Given this list of marker genes HNRNPH2, KMT2A, ZNF263, CDCA7L, DMD, POU3F2, JADE1, ZCCHC14, VCL, H4C3, MARCHF1, SEC14L1, HPSE2, OR2L13, JMJD1C, NKX2-8, TTLL10, ANKS1B, JOSD1, ANKS1A, CELF6, IKZF5, PRDM13, ADRB2, MAP2K5, TAF11, MBNL1, CBX8, TMEM187, ASIC1, NPAS2, EDA, PDZD7, FOXN3, CDH16, KRTAP17-1, LRRFIP2, HDAC9, PDE10A, RBM3, KCNE4, PCYT1B, ITGB3BP, ACADSB, CEP95, MAP1A, MIOX, ACTN4, FOXG1, TAF5, RNF128, FOXP2, BEND4, GLA, NIPBL, UBASH3B, FLRT1, SPRR1A, HOXA10, here is a description of the gene set: Genes having at least one occurrence of the motif NNNNGTCANGNRTKANNNN in the regions spanning 4 kb centered on their transcription starting sites. This matches the PAX2 transcription factor binding site V$PAX2_01 (v7.4 TRANSFAC). studied in species Homo sapiens Human Gene Set: PAX2_01